The following is a description of a gene set: An elevated urine level of a compound that is derived from an amino acid. Human Gene Set: HP_INCREASED_URINE_PROTEINOGENIC_AMINO_ACID_DERIVATIVE_LEVEL species: Homo sapiens Increased urine proteinogenic amino acid derivative level, and this is the list of marker genes: PHYKPL, SLC25A13, HAL, GSS, MOCS2, MOCS1 (molybdenum cofactor synthesis 1), OPLAH, ASL, IVD, ACAT1, GPHN